Given this list of marker genes P2RY10, CDK13 (NCBI Gene Id 8621), NFYB, CACNB2, TBX19, IMPA1, TMEM11, TTLL5, NTNG2, BTD (biotinidase), CTRL, HTR7, TMEM94, SLC24A1, EXTL3, KIAA0586, TMEM184B, PIK3CB, RNF14, ERCC2, AQP7, AMMECR1 (NCBI Gene Id 9949), TFDP2, SYT5, PARVB, KRT33A, MICAL3, FIG4, CNTN6, CLPX, WIPF2, CAMK2G, PTEN, NTPCR (nucleoside-triphosphatase, cancer-related), NR2C1, MGA, SLC30A3, ZNF710, GRIK5, DAPK2, SULT2B1 (NCBI Gene Id 6820), PLEKHB1, TTI1, CPSF4, SLC35B1, JRK, ITIH4, KANK3, CHD9, ZNF133, C1orf216, GSK3B, ZNF500, LTBP4, BRCA1, PPP2R5B, GJB5, POU6F2, COX6A2, CSTF3, GPATCH8, NR1I2, CHD3, NUMB, RPS6KA5, SEZ6L, PPP1R3D, GRIP2, LPGAT1, FOSL1, UPK1A, WDR47, KLHL18, HOXD4, SCAMP1, ZNF134, DTNA, FRYL, TANC2, OSR1, ATRX, FNTB, GPR15 (G protein-coupled receptor 15), ZNF32, CNKSR1, OARD1, IKBKE, CPEB3, ARHGAP12, TAF2, ZP2, MSL3, SLC16A5, ARFGEF2, SPAST, WBP4 (WW domain binding protein 4), TMCC1, POLR2K, RUNX1, PCF11, ADCY3, TBC1D22A, NKRF, KANK2, UTRN, BPHL, NCKIPSD, AMFR, PIGF, EP400 (NCBI Gene Id 84442), OR2F1 (NCBI Gene Id 26211), MT4, POFUT2, BARX2, CDYL, EPHB2, DNAJC16, PAX9, TAF5L, TBCE (tubulin folding cofactor E), SLC33A1, KRR1, ERC1, BRD1, CACNB1, NMT1, PIGR, PAXIP1, BNIP1, SMG1, FUT6, IL13, CYP11A1, POU6F1, KLHDC10, UBE4B, DPT, ESR1, PSMF1, RBBP8, PRELID3A, ZNF592, GARRE1, PHF10, MC5R, PHF21A, DIMT1, MSH3, REV3L, ZBTB22, SLC4A3, ATP6V0A2, TRIM24 (tripartite motif containing 24), ZBTB17, NFX1, KRT86, ST13, POP4, GLE1, MFN1, INPP5E, COLQ, SULT4A1, IFT27, PIAS2, GPR19, NRTN, here is a description of the gene set: studied in species Homo sapiens Neighborhood of PSMF1 proteasome (prosome, macropain) inhibitor subunit 1 (PI31) in the MORF expression compendium Neighborhood of PSMF1 Human Gene Set: MORF_PSMF1